Given this list of marker genes Numa1 (nuclear mitotic apparatus protein 1), Map10, Aurkb, Birc5, Prc1, Racgap1, Incenp, Cdca8, Kif4, Kif23, here is a description of the gene set: The cell cycle process in which the distance is lengthened between poles of the mitotic spindle. Mitotic spindle elongation begins during mitotic prophase and ends during mitotic anaphase B. studied in species Mus musculus Mouse Gene Set: GOBP_MITOTIC_SPINDLE_ELONGATION